The following is a description of a gene set: Human Gene Set: HP_MICROPENIS species: Homo sapiens Abnormally small penis. At birth, the normal penis is about 3 cm (stretched length from pubic tubercle to tip of penis) with micropenis less than 2.0-2.5 cm. Micropenis, and this is the list of marker genes: SLC30A7, POMT2, FILIP1, MAP3K1, PIGP (NCBI Gene Id 53821), FGF17, C2CD3, OTX2, PIGQ, FANCL, AR, FAM111A, PTPN11, LHB, SRD5A2, RNU7-1, MAGEL2, PSMD12, DVL1, SRA1, UBA1, ELN, UBR1, GLI2, SRRM2, ALG12, UBE2A, BLTP1, TBC1D20, CDC45, ATP6V1E1 (ATPase H+ transporting V1 subunit E1), SEMA3E, SAMHD1, BBS1, ALMS1, KMT2D, B4GAT1, HERC1, ECE1, ERCC2, SRY, FLRT3, LEP, DCAF17, TBL1XR1, SNORD116-1, TREX1, FGF8, IFT172, SPRY4, NR5A1, DCC, RNASEH2B, CTU2, ATAD3A, SIK1, AXL, DMXL2, SLC32A1, EHMT1, NEUROD2, ACTA1, KLHL41, WNT5A, KISS1R, GLYCTK, DYNC2H1, WWOX, PRKDC, STT3B, CUL4B, PWAR1, POGZ, GLI3, INPP5E, CAMK2A, DCX, GRIA3, ARMC9, KAT6B, NDNF, FKRP, EIF2S3, GRIN1, TBCE, ARL6, OTUD5, ARCN1, POR, NSMF, TRIM8, BBS5, CCDC141, STXBP1, PRDM13, BBS2, RYR1, KLHL15, SMCHD1, OPHN1 (NCBI Gene Id 4983), SLC25A22, GH1, CEP41, SCN1B, LSS, WT1, FGFR1, NR0B1, SOX10, FANCD2, BUB1B, ARX, DNA2, CPE, HESX1 (NCBI Gene Id 8820), HDAC8, CDH2, RSPO2, LSM11, RAB3GAP2, TP63, KIAA0586, FEZF1, TCF12, SOX2, H4C9, TCF4, LMX1B, CHD7, MYRF, POLE, DDX6, LIG4, SIM1, FRAS1, MINPP1, DVL3, PPP1R12A, PIGA, NHLH2, GNB2, PNKP, TBX3, PIEZO2, DHX37 (DEAH-box helicase 37), MBD5, MEGF8, SATB2, DPYSL5, GNAO1, KDM6A, NPAP1, VAMP7, SOX9 (NCBI Gene Id 6662), MADD, GRM7, FAT4 (FAT atypical cadherin 4), B9D2, NEK1, MAMLD1, TAC3, ZFPM2, RIPK4, POMT1, SNORD115-1, HNRNPR, AHDC1, SGPL1, SETBP1, EXT2, HSD3B2, TWIST2, XRCC4, CENPT, ERCC8, ALKBH8, ZPR1, ATP6V1A, CDH11, ANOS1, CASK, PROKR2, IL17RD, FZD2, HS6ST1, LZTFL1, KDM5C, MLXIPL, UBR7, FIG4, CDC6, CCDC28B, SMO, EBF3, CHD4, SLC25A24, DUSP6, ATRX, ALX4 (NCBI Gene Id 64068), DYRK1A, RNU4ATAC, RAB18, ERCC6, WDR11, CDC42BPB, LARGE1, RLIM, COLEC10, PBX1, SEMA3A, MED12, VAC14, ROR2, KLHL40, COG5, HCCS, CYP17A1, USP7, PSMC1, LAMA5, FANCB, SLC29A3, SIX6, GMPPB, RNASEH2A, KCNA1, THOC6, ZEB2, ADAT3, HERC2, PHF21A, TRPM3, KISS1, TOGARAM1, KATNIP, COX7B, KIF7, CYB5A, RNF113A, STT3A, CDKL5, PHF6, IFIH1, KIAA0753, MCTP2, LMOD3, SCN2A, KLF1, GNRH1, PNPLA6, TACR3, RNASEH2C, ORC1, GNRHR, PROK2, TAPT1, TOE1, DHCR7, ACTB, NDUFB11 (NCBI Gene Id 54539), HUWE1, DTYMK, ADAR, HOXA13, LMNB2, MYT1L, THOC2, GATA4, HID1, INTU, ORC6, DHODH, MID1, DHDDS, MKRN3, CDKN1C, SPTBN1, MTM1, NEB, PWRN1